The following is a description of a gene set: Genes up-regulated during transition from G2 (moderately differentiated tumor, infected with HCV) to G3 (poorly differentiated tumor, infected with HCV) in the development of hepatocellular carcinoma. studied in species Homo sapiens Human Gene Set: IIZUKA_LIVER_CANCER_PROGRESSION_G2_G3_UP from publication Iizuka N, Oka M, Yamada-Okabe H, Mori N, Tamesa T, Okada T, Takemoto N, Sakamoto K, Hamada K, Ishitsuka H, Miyamoto T, Uchimura S, Hamamoto Y (PMID 15710396) Using high-density oligonucleotide array, we comprehensively analyzed expression levels of genes in 50 hepatocellular carcinoma (HCC) samples with positive hepatitis C virus (HCV) serology (well (G1), moderately (G2), and poorly (G3) differentiated tumors) and 11 non-tumorous livers (L1 and L0) with and without HCV infection. We searched for discriminatory genes of transition (L0 vs. L1, L1 vs. G1, G1 vs. G2, G2 vs. G3) with a supervised learning method, and then arranged the samples by self-organizing map (SOM) with the discriminatory gene sets. The SOM arranged the five clusters on a unique sigmoidal curve in the order L0, L1, G1, G2, and G3. The sample arrangement reproduced development-related features of HCC such as p53 abnormality. Strikingly, G2 tumors without venous invasion were located closer to the G1 cluster, and most G2 tumors with venous invasion were located closer to the G3 cluster (P=0.001 by Fisher's exact test). Our present profiling data will serve as a framework to understand the relation between the development and dedifferentiation of HCC., and this is the list of marker genes: SDC1, HADH, FBXW11, BNIP3, BAAT, KDELR2, RARRES2, PAH, FOXN3, CPB2, SCML2, PRDX6, SELENOP (selenoprotein P), TMED2, APOC1, FERMT2 (NCBI Gene Id 10979), ACSL1, COBLL1, SDHD, TIMM17A, CCL5, ACSM2B, PGRMC1, RAPGEF2, GPLD1, PCSK6 (proprotein convertase subtilisin/kexin type 6), PPM1A (NCBI Gene Id 5494)